Given this list of marker genes PNPLA6, STOML2, ABCC5, WBP1L, PCYT2, CEP41, SAP130 (NCBI Gene Id 79595), TSNAXIP1, FOXO4, HOXC4, MRPL50, CDKL5, MRPL34, SRSF2, IPO13, ZNFX1, SMPD3, LYSMD1, BET1, ZNF582, ZNF568, FEM1A, KLF9, CTCF, GFUS, ANP32E, ZNF571, OTP, PI15, MINDY1, POU2AF1, PLP2 (NCBI Gene Id 5355), CHMP4B, SHKBP1, GSK3A, MON1A, CDIN1, ENOX2, HGF, CTF1, FOXA3 (forkhead box A3), HHAT, SIX1, SGF29, MPI, NEUROD6, MKNK1, SAV1, MRPL54, ADAM22, PRUNE1, IRF2BP1, BABAM1, APBA3, PURA, DPYSL2, ZFP2, LINC00487, BCLAF3, CSRNP2, SUPT6H, TMED5, PAX6, CD99L2, DRC7, TGFBI, ZNF570, ZNF485, ZNF189, SYMPK (symplekin scaffold protein), TYRO3, PSMC3, POC1A, CLPB, MIR137HG, NSD3, MED15, CRISP1, DLX1, RNF121, JAK1, FBXW7, DCAF1, SLITRK5, TNRC6A (trinucleotide repeat containing adaptor 6A), CARF, OGG1, MARS1, MISP, HMBOX1, EIF4G1, ZNF569, DCDC1, PDLIM7, TRMT1L, DDX25, DTX2, ZNF546, TNKS2, NFATC4, PRAF2 (NCBI Gene Id 11230), PRPF19, CKM (creatine kinase, M-type), PDE6D, VPS41, HSD17B4, COX7B, HIGD2A, POLR1B, HOXA5, MOS, PUS3, SCNM1, UBE2N, NOP16, ARHGAP9, ASIC2 (acid sensing ion channel subunit 2), GPX1, RNF220, C8orf82, ZNF420, RDH11, TRPS1, CITED2, SDF2, SWT1, INVS, INTS9, ERG, RANBP10, here is a description of the gene set: Human Gene Set: RACTNNRTTTNC_UNKNOWN Genes having at least one occurrence of the highly conserved motif M66 RACTNNRTTTNC in the regions spanning 4 kb centered on their transcription starting sites. The motif does not match any known transcription factor binding site. species: Homo sapiens from publication Xie X, Lu J, Kulbokas EJ, Golub TR, Mootha V, Lindblad-Toh K, Lander ES, Kellis M (PMID 15735639) Comprehensive identification of all functional elements encoded in the human genome is a fundamental need in biomedical research. Here, we present a comparative analysis of the human, mouse, rat and dog genomes to create a systematic catalogue of common regulatory motifs in promoters and 3' untranslated regions (3' UTRs). The promoter analysis yields 174 candidate motifs, including most previously known transcription-factor binding sites and 105 new motifs. The 3'-UTR analysis yields 106 motifs likely to be involved in post-transcriptional regulation. Nearly one-half are associated with microRNAs (miRNAs), leading to the discovery of many new miRNA genes and their likely target genes. Our results suggest that previous estimates of the number of human miRNA genes were low, and that miRNAs regulate at least 20% of human genes. The overall results provide a systematic view of gene regulation in the human, which will be refined as additional mammalian genomes become available.